Given this list of marker genes Nme6, Ak3, Uck1, Entpd7 (ectonucleoside triphosphate diphosphohydrolase 7), Nme7, Entpd4b, Nme5, Uck2, Cad, Nme2, Entpd4, Nme4, Ctps2, Ctps1, Nme1, Nme3, here is a description of the gene set: Mouse Gene Set: GOBP_PYRIMIDINE_RIBONUCLEOSIDE_TRIPHOSPHATE_METABOLIC_PROCESS studied in species Mus musculus The chemical reactions and pathways involving pyrimidine ribonucleoside triphosphate, a compound consisting of a pyrimidine base linked to a ribose sugar esterified with triphosphate on the sugar.